The following is a description of a gene set: Human Gene Set: MIR208B_5P Genes predicted to be targets of miRBase v22 microRNA hsa-miR-208b-5p in miRDB v6.0 with MirTarget v4 prediction scores > 80 (high confidence targets). from publication Chen Y, Wang X (PMID 31504780) studied in species Homo sapiens, and this is the list of marker genes: DCN, HDAC9, SERP1, NEFL, CDC14A, SLC25A43, RALYL, JMJD1C, LYN, DEGS1, TET1, TNRC6C, AQP4, SLC44A1, DSN1, SNTB2, RORA, ZFP36L1, ADAM23, SKP2, SIRT1, NT5C1B-RDH14, NMBR, FAM120B, DENND1B, GPD1L, UNC80, MBLAC2, GRIK2, G2E3, UBE2B, AFAP1, SMARCA1, KLHL41, DSCAM, SMIM17, SMAD2, PTPN11, CYSLTR1, ZNF704, MTX3, SPARC, SGK3, TSEN34, TLE3, VPS13A, SMC2 (structural maintenance of chromosomes 2), MFAP3, CNIH4, AP5M1, MTHFD2L, VSIG10, ZNF280C, RNF38, GLS, PGD (NCBI Gene Id 5226), ZFR, HAND1, FUT9, NOG, MMP19, MRPS28, CTHRC1, USP13, FERRY3, PRRC1, KIAA1549, CD83, PIK3R1, PPP3CA, TLL1, ITGA2, ARG1, STXBP1, GUCY2C, FHIP2A, ME1, MAP3K2, ZNF483, HIC2, TC2N, UTY, RNF11, CNTN4, PRKRA, ZNF507, ABHD18, MAP3K21, TOR1AIP1, RAB11FIP2, MBD4, TSC22D2, MAP4K5, ROCK2, DEUP1, SMARCA2, ZNF816-ZNF321P, SLITRK4, HMGN2, ZNRF3, RFWD3, KCNQ3, CLOCK, MBD2, AK7, MTF1, RAPGEF6, STC2, MSI2 (NCBI Gene Id 124540), PLAC9 (placenta associated 9), ABTB3, SLC12A6, ALDH1L2 (aldehyde dehydrogenase 1 family member L2), ZKSCAN1, REXO2, PPHLN1, PTK2, RECK, CCDC66, EYA4, DAB2, PDIK1L, CCNJ, MDN1, CDC73, ZNF568, TMEM170B (transmembrane protein 170B), PDS5B, ODR4, ZNF823, CPEB2, LONRF1, ENOSF1, ITGB8, SDE2, STARD4, CERT1, WEE2, ST8SIA4, ZBTB20, GLCCI1, NEUROD6 (neuronal differentiation 6), SASH1, CTNND2 (catenin delta 2), UBE2K, PTPRE, NEDD1, FBXW7, HNF4G, PKNOX1, TTC1, SLCO1A2, PRXL2C, ADGRA2, PHF20L1, JAM3, TPST1 (tyrosylprotein sulfotransferase 1), SLC35A5, TFE3, MXI1, GUCY1A1, RNF111, USP47, STC1, TIMM8A, SUZ12, ADCY3, RPS6KA6, CTXN1, UBE2N, GTPBP10, ACSL4, CDK1, PECR, MFAP3L, XPO5, KRR1, AGTR2, MRS2, AFF4, HNRNPA2B1, EPHX2, MDH2, TBX18, TRAPPC13, AK4, SPRY3, SLK, ADCY1, SNX3, SCOC, ADAMTSL3, GPRC5B, SRPK2, ZNF280D, FGFR1OP2, NUFIP2, NR3C1, GNAI3, IER5, PLPP3, ADORA3, GRP, MDK, PROX1, HOXC4, ABCG1, GABRA1, KAT6B, SPDYA, CCNYL1, KCNV1, SAMD4A, SYCP2, HMGN3, TENT2, RHOQ, TLCD4, LRP2BP, ARID4B, STAG1, DTHD1, PAIP2, ZDBF2, TRA2A, CLTC, TNPO1, PSMA8, ING4, ZNF443, MARCHF4, ZBTB43, C8orf44-SGK3, ANK2, ZNF781, PCDH8 (protocadherin 8), LATS1, JAZF1, SSX2IP, JAKMIP3, EIF5, CNOT8 (NCBI Gene Id 9337), SLC17A6, MTM1, ZNF799 (NCBI Gene Id 90576), CRBN, ZMYND11, FAM118B, FAM107B (NCBI Gene Id 83641, family with sequence similarity 107 member B), CDR2 (NCBI Gene Id 1039), FREM2, GABRB2, ARRDC5, TCF15, CCDC126, SLC23A2, RNF149, CUL4A, UFC1